Given this list of marker genes OTUB2, OTUD7B, TRAF3, UBE2D1, TP53, RPS27A, PTEN, UBB, RIGI (RNA sensor RIG-I), OTUD3, IKBKG, ZRANB1, RIPK2, IFIH1, YOD1, CDK1, TRIM4, VCP, RNF128, NOD2, NOD1, VCPIP1, OTUB1 (OTU deubiquitinase, ubiquitin aldehyde binding 1), TNFAIP3, UBC, OTUD5, APC, TRAF6, TNIP3, RIPK1, MAVS, TNIP1, UBA52, ESR1, TRIM25, TNIP2, RHOA, RNF135, OTUD7A, here is a description of the gene set: part of: Deubiquitination studied in species Homo sapiens Reactome Pathway: Ovarian tumor domain proteases Humans have 16 Ovarian tumour domain (OTU) family DUBs that can be evolutionally divided into three classes, the OTUs, the Otubains (OTUBs), and the A20-like OTUs. <br> <br>OTU family DUBs can be highly selective in the type of ubiquitin crosslinks they cleave. OTUB1 is specific for K48-linked chains, whereas OTUB2 can cleave K11, K63 and K48-linked poly-Ub. A20 prefers K48-linked chains, Cezanne is specific for K11-linked chains, and TRABID acts on both K29, K33 and K63-linked poly-Ub. The active site of the OTU domain contains an unusual loop not seen in other thiol-DUBs and can lack an obvious catalytic Asp/Asn (Komander & Barford 2009, Messick et al. 2008, Lin et al. 2008). A20 and OTUB1 have an unusual mode of activity, binding directly to E2 enzymes.